Given this list of marker genes CHRNB4 (NCBI Gene Id 1143), CHRNA1, CHRNE, CHRNA5, CHRNA7, CHRNA2, CHRNA4, CHRND, CHRNB3, CHRNA9, CHRNB2, CHRNA3, CHRNG, CHRNA6, here is a description of the gene set: Human Gene Set: REACTOME_ACETYLCHOLINE_BINDING_AND_DOWNSTREAM_EVENTS studied in species Homo sapiens Acetylcholine binding and downstream events